Given this list of marker genes Rhox2c, Rhox2e, Rhox2f, Rbm25, Rhox2b, here is a description of the gene set: Mouse Gene Set: MIR_6546_5P studied in species Mus musculus from publication Chen Y, Wang X (PMID 31504780) Genes predicted to be targets of miRBase v22 microRNA mmu_miR_6546_5p in miRDB v6.0 with MirTarget v4 prediction scores > 80 (high confidence targets).